Given this list of marker genes PTPN11, UBC, UBB, SPRY2, SRC, PPP2CA, PPP2R1A, UBA52, MKNK1, RPS27A (ribosomal protein S27a), PPP2CB, MAPK3, GRB2, BRAF, MAPK1, CBL, here is a description of the gene set: Spry regulation of FGF signaling studied in species Homo sapiens Human Gene Set: REACTOME_SPRY_REGULATION_OF_FGF_SIGNALING